The following is a description of a gene set: species: Mus musculus This event has been computationally inferred from an event that has been demonstrated in another species.<p>The inference is based on the homology mapping from PANTHER. Briefly, reactions for which all involved PhysicalEntities (in input, output and catalyst) have a mapped orthologue/paralogue (for complexes at least 75% of components must have a mapping) are inferred to the other species. part of: RAF/MAP kinase cascade Reactome Pathway: Regulation of RAS by GAPs electronically inferred by orthology from the curated human pathway, and this is the list of marker genes: Ubb, Psma7, Psmd1, Psmd7, Psmc3, Psma3, Rasal1, Psmc1, Psma4, Psmb7, Psma6, Hras, Psmc2, Rasa1, Psma1, Psmb4, Psmb5, Psmd6, Psmd12, Psmc4, Rasal3, Psma5, Spred3, Psmd13, Rps27a, Psmc6, Psmb6, Psmc5, Rasa4, Psma2